Given this list of marker genes TOR1AIP1, MORF4L1, MBD3, AAAS, ERG28, GATAD2A, DDX17, GPBP1, SIN3A, MTMR7 (NCBI Gene Id 9108), CHUK, PSME3, UBR7, COMMD9, CPSF4, ACOT8, S100PBP, SPG21, MTMR4, PRPF8, BOD1L1, IPO5, GFM2, MCM4 (NCBI Gene Id 780917), ANAPC5, ALKBH5, POLDIP3, DENR, C1orf52, ACAD11, MED17, DDX47, TEX261, TMEM167B, TBC1D14, CCZ1B, ARFGAP1, REPIN1, DENND4A, NF2, CCAR1, CS, TMEM39B, SUMF2, DDA1, CHFR, ABHD16A, PCNP, ZNF317, AK4, here is a description of the gene set: Human Gene Set: GCM_DENR Neighborhood of DENR density-regulated protein in the GCM expression compendium Neighborhood of DENR species: Homo sapiens